Given this list of marker genes Atp6v1f, Coq2, Snx1, Atr, Atp6v1h, Coq4, Atp6v1g2, Atp6v1a, Rph3a, Syn1, Tprg1l, Atp6v1e1, Dusp18, Cltc, Atp6v1c1, Tepsin, Amph, Snap29, Syn2, Syn3, Sgta, Coq8a, Tamm41, Gripap1, Atm, Atg14, Nucb1, Coq6, Atp6v1d, Cadps, Zfyve1, Coq3, Stxbp5, Atp6v1g1, Atp6v1b2, Coq5, Emc2, Atp6v1b1, Doc2a, Coq7, Doc2b, Bin1 (bridging integrator 1), Snx10, Btbd8, here is a description of the gene set: Mouse Gene Set: GOCC_EXTRINSIC_COMPONENT_OF_ORGANELLE_MEMBRANE The component of an organelle membrane consisting of gene products and protein complexes that are loosely bound to one of its surfaces, but not integrated into the hydrophobic region. studied in species Mus musculus